The following is a description of a gene set: Genes having at least one occurrence of the highly conserved motif M102 ATGGYGGA in the regions spanning 4 kb centered on their transcription starting sites. The motif does not match any known transcription factor binding site. studied in species Homo sapiens Human Gene Set: ATGGYGGA_UNKNOWN Comprehensive identification of all functional elements encoded in the human genome is a fundamental need in biomedical research. Here, we present a comparative analysis of the human, mouse, rat and dog genomes to create a systematic catalogue of common regulatory motifs in promoters and 3' untranslated regions (3' UTRs). The promoter analysis yields 174 candidate motifs, including most previously known transcription-factor binding sites and 105 new motifs. The 3'-UTR analysis yields 106 motifs likely to be involved in post-transcriptional regulation. Nearly one-half are associated with microRNAs (miRNAs), leading to the discovery of many new miRNA genes and their likely target genes. Our results suggest that previous estimates of the number of human miRNA genes were low, and that miRNAs regulate at least 20% of human genes. The overall results provide a systematic view of gene regulation in the human, which will be refined as additional mammalian genomes become available. from publication Xie X, Lu J, Kulbokas EJ, Golub TR, Mootha V, Lindblad-Toh K, Lander ES, Kellis M (PMID 15735639), and this is the list of marker genes: TMEM222, CACNA2D2, NDST2, APBB3, FGD4, PHC3, C1orf43, BRCA1, CRKL, PRPS1, CCNA2, SLC35A4, TMEM208, THAP1 (THAP domain containing 1), ARMCX6, EXOC6 (NCBI Gene Id 54536), SLC20A1, FOXA3, SWSAP1, SPRED1, NUFIP2, VASP, EFNB3, PPP4R3A, LIN54, MRPS18B, ELMOD1, YWHAZ, KPNA6, EPC1, COG4, ATP1A3, GABPB2, CSNK1A1, CLTC (clathrin heavy chain), TBC1D16, BDNF, FASTK, GNAO1, KIF9, WASF2, LRRC36, KDM3A, POU2F1, OTUD7B, NHLH2, C19orf48P, XIAP, HOXA3, MDH1, NBEA, PPP3CB, SH3KBP1, TRA2B, DOCK5, DLG3, CD3E, TMEM187, E4F1, MTFP1, ADGRL3, HNRNPH2, RGS17, RALGAPA1P1, ZNF711 (NCBI Gene Id 7552), PAN2, MAP2, ZMYM2, UBALD1, EPC2, GLA, FBXL9P, STAG2, SF3B3, NAA15, TSHZ2, BCL11B, PBX1, CAMSAP1, ARIH1, WDR33, EXT1, KCNK18, ATG101, PPP4R3B, PPP1R10, CGGBP1, CBX6, GARNL3, SFPQ (NCBI Gene Id 6421), PURA, SYMPK, PIAS3, WDR53, NBR2, KLHL18, SLAIN1, PPP1R21, TSSK3, TUBA1A, RBBP6, PTBP1, YTHDF3, NONO, OTX2